Given this list of marker genes STC1, PPP3R1, PLEKHA5, PAWR, EGR3, SKAP2, ZNF407, IL17C, THBD, RASL11A, ANXA1, NAA15, DIO2, PLLP, NPIPB3, MAP3K2, DNAJC3, MYNN, AQP2, SATL1, MALAT1, CALM1, JAK3, CCDC18, C6orf62, ARHGEF7, DNAJC7, C5orf22, EIF4B, S100A3, PLCG1, HNRNPM, ZNF638, IFNGR1, GNAS, XIST, SLC37A3, HNRNPU (NCBI Gene Id 3192), STMN3, THUMPD3, CDK13, SGCD (NCBI Gene Id 6444), GALNT7, TAF4B, EMILIN3, SNX22, TP53, TRPS1, EPO, here is a description of the gene set: Human Gene Set: STAMBOLSKY_TARGETS_OF_MUTATED_TP53_UP species: Homo sapiens The p53 gene is mutated in many human tumors. Cells of such tumors often contain abundant mutant p53 (mutp53) protein, which may contribute actively to tumor progression via a gain-of-function mechanism. We applied ChIP-on-chip analysis and identified the vitamin D receptor (VDR) response element as overrepresented in promoter sequences bound by mutp53. We report that mutp53 can interact functionally and physically with VDR. Mutp53 is recruited to VDR-regulated genes and modulates their expression, augmenting the transactivation of some genes and relieving the repression of others. Furthermore, mutp53 increases the nuclear accumulation of VDR. Importantly, mutp53 converts vitamin D into an antiapoptotic agent. Thus, p53 status can determine the biological impact of vitamin D on tumor cells. from publication Stambolsky P, Tabach Y, Fontemaggi G, Weisz L, Maor-Aloni R, Siegfried Z, Shiff I, Kogan I, Shay M, Kalo E, Blandino G, Simon I, Oren M, Rotter V (PMID 20227041) Genes induced in SKBR3 cells (breast cancer) by mutated TP53.